The following is a description of a gene set: Human Gene Set: REACTOME_ATTACHMENT_OF_GPI_ANCHOR_TO_UPAR Attachment of GPI anchor to uPAR species: Homo sapiens, and this is the list of marker genes: PIGU, PGAP1, GPAA1, PLAUR, PIGK, PIGT, PIGS